The following is a description of a gene set: The process in which relatively unspecialized cells acquire specialized structural and/or functional features that characterize the cells of the metanephric nephron tubule as it progresses from its formation to the mature state. Mouse Gene Set: GOBP_METANEPHRIC_NEPHRON_TUBULE_EPITHELIAL_CELL_DIFFERENTIATION species: Mus musculus, and this is the list of marker genes: Lif (NCBI Gene Id 16878), Pax2 (NCBI Gene Id 207129), Fat4, Pax8, Yap1 (yes-associated protein 1), Stat1, Wwtr1